The following is a description of a gene set: Pace of progression studied in species Homo sapiens Human Gene Set: HP_PACE_OF_PROGRESSION, and this is the list of marker genes: POMGNT1, SLC5A7, TEAD1, PTRH2, TRAPPC6B (trafficking protein particle complex subunit 6B), SLC20A2, PABPN1, VWA3B, MAP3K20, ISCA1, ALS2, PRX, CYP7B1, KMT2B, HNRNPDL, CHKB, LRRK2, MORC2, PRKRA (protein activator of interferon induced protein kinase EIF2AK2), STARD7, LAMA2, KCNT1, FIG4, UMOD, POLG2, FBXO38, KPNA3, ADA2, MFN2, SEC61A1, SLC52A3, SETX (senataxin), SPAST, XRCC1, LRP12, POLR3B, TTN, PDE8B, CHRND, COASY, GBA2, LMNA, HSPB3, CHRNE, TRPC3, TGM6, KLC2, C9orf72, IGHMBP2, CCNO, HNRNPA1 (NCBI Gene Id 780920), PSEN1, SLC52A2, TJP2, NAXE, MED17, MOCS2, COQ6 (coenzyme Q6, monooxygenase), DARS1, ERLIN2, GDAP1, FAT2, SLC9A1, HK1, WASHC5 (NCBI Gene Id 9897), PDYN, REEP2, SLC33A1, PRICKLE1, ATXN8OS, ALG2, PMP22, BSCL2, ANO5, LYRM7, FLNC, PLEC, ATP11A, GRM1, INPP5K, JAG2, CRAT, VPS53, ZFYVE26, HLA-DQB1, MYH14, MRPS34, UCHL1, SAMD12, COCH, PKD2, COPB2, KIF1B, REPS1, KCNC1, DGKE, NEFH, TOR1AIP1, FAN1, DNAJC6 (DnaJ heat shock protein family (Hsp40) member C6), BAG3, SCN8A, TBCE, POLR3A, ITPR1, EPM2A, DRD3 (NCBI Gene Id 2111), SLC6A3, MYOT (NCBI Gene Id 9499), NDUFA13, LMNB2, PYCR2, NUP133, MAPT, GJB1 (NCBI Gene Id 95372), ATP6AP2, PNPLA8, MECR, CCDC88C, DARS2, TXN2, LAMB1, SPRY2, GEMIN5, EMC1, NLRP3, NIPA1, SLC25A4 (NCBI Gene Id 7872), NDUFS1, MAG, EEF2, SPG21, ANTXR2, NDUFAF2, SIGMAR1, KIF1A, AIMP1, SNORD118, PRKCG, ALG14, NR1H4, CACNA1A, ABCD3, PEX10, CAD, MCM2, KCNK3, DEGS1, SMN1, SLC12A6, VRK1, PIEZO2 (piezo type mechanosensitive ion channel component 2), FHL1, COL4A5, TRAPPC12, TRAPPC2L, ATP7A, MTAP, PMPCA, GAN, ACTA1, DDHD1, ATXN2, MCM3AP, TRAK1, PLP1, PEX16, MTPAP, MPV17, DCDC2, CWF19L1, KCTD7, DAB1, MYORG, PARK7, VPS13A, PCLO, GDAP2, SYT14, PLCE1, CLPB, CHCHD10, PCNA, COQ8B, NDUFB9, ORAI1, PANK2 (NCBI Gene Id 80025), FKTN, WT1, CLN8, PINK1, CRPPA, PDGFRB, COX6A1, YARS2, SNCAIP, SYNE1, PRDM8, ASNS, SGPL1, HPDL, DNA2, SLC44A4, ATAD1, PLD3 (NCBI Gene Id 23646), RTN2, AR, ATP1A1, MAP2K1, PLEKHG5, VCP, B4GALNT1, STUB1, DDHD2, CTC1, AP4B1, AIFM1, GNB4, COL6A1, TPP1, FARS2, RRM2B, TUBB6, DIABLO, HSPB1, SOX18, FN1, SMN2, ADH1C, ATL1, RETREG1, DYSF, PMPCB, PIK3R5, NAGLU, MYH7, NEFL, FBXO7, MAPKBP1, DNAJB11, OPA1, MRE11, CFL2, GBE1, CACNA1G, VAC14, DNAJB2, POMT1, ADSS1, KY, SLC39A14 (solute carrier family 39 member 14), YEATS2, KCND3, EMD, ERLIN1, SYNJ1, ACER3, MARS1, MARCHF6, MTMR14, ABCD1, AGTPBP1, PMP2, COL4A4, AAAS, BRAT1, SURF1, TBK1, QARS1, ATXN3, TRIM32, FRG1, DZIP1L, ALDH18A1, KIF5A, ELOVL5, NUP85, ARHGDIA, MICOS13, STIM1, BET1, TWNK, HSPD1, PRUNE1, AP5Z1, VLDLR, HINT1, KCNQ4, MECP2, CFHR5, DNAJB6, MFSD2A, WNK1, ATP13A2 (NCBI Gene Id 63919), GFPT1, UBA5, TYMP, MFF, GNS, KCNC3, NUP107, C19orf12, POGLUT1, KIF1C, TRPV4, SPTBN2, COL6A2, CTSF, KBTBD13 (NCBI Gene Id 651356), NR4A2, TUBB4A, CRYAB, COL4A3 (NCBI Gene Id 200750), DYNC1H1, DMXL2, RUBCN, GYG1, TNFRSF11B, PEX2, SCARB2, SCN9A, ABHD12 (abhydrolase domain containing 12, lysophospholipase), SPG11, GRHL2, NDUFA12, DPM1, SGCG, NKX6-2, TBP, PLA2G6, TBC1D24, RNASEH2C, RBCK1, TFG, KCTD17, FGF14, ELP2, GRN, GOSR2, IBA57, TMEM43, ACTN4, HOXB1, MFSD8, IREB2, PNKP, CPT1C, PNPLA6, EXOSC9, SLC34A2, LRSAM1, FZD4, UBQLN2, MTRFR, ELMO2, COQ2, SMAD9, FA2H (NCBI Gene Id 79152), LIMS2, POLG, ILDR1, RARS2, XPR1, EPRS1 (NCBI Gene Id 2058), PNPLA2, DNMT1, NUP93, SQSTM1, DNM1L, RFC1, VPS13C, LRP5, MYMK, APOE, CLCN5, NBEAL2, ATN1, ISCA2, MT-TT, CLDN14, GARS1, DCTN1, VMA21, SOST, PDK3, NDUFS7, NPHS2, ASAH1, NUP214, ATG5, AFG3L2, MOCS1, GPT2 (NCBI Gene Id 84706), DPAGT1, PYROXD1, HEPACAM, FTL, TTR, OPTN, GNAS, RYR1, ATP2B3, TMEM240, FLVCR1, NUP160, HPCA, MGME1, TARDBP, SBF1, PDGFB, SNCA, DNAJC5, TK2, TFAM, CERS1, MPZ, RNASEH1, IRF2BPL, KRT12, WARS1, RNASET2, NOL3, TREX1, ADK, PRNP, CSF1R (NCBI Gene Id 8156), GBA1, MYO1E, TNFRSF11A, TIA1, ELP1, SGCA, COA7, NOP56, WDR45B, NPHS1, AKT1, AIMP2, INF2, FZD6 (NCBI Gene Id 8323), DNM2, AARS2, MYPN, VARS1, PDE10A, MME, NALCN, PDXK, TENM4